The following is a description of a gene set: Mouse Gene Set: GOBP_REGULATION_OF_DENDRITIC_SPINE_MAINTENANCE species: Mus musculus Any process that modulates the frequency, rate or extent of dendritic spine maintenance., and this is the list of marker genes: Nedd9, Zmynd8, Vps35, Apoe, Fcgr2b, Homer1, Grin2b, Prnp, Ins1, Zfp804a, Ins2, App, Abhd17b, Fyn, Grin1, Cfl1 (NCBI Gene Id 12631)